Given this list of marker genes BCL2A1, TRABD, MSTO1, PRKN, THG1L, PID1, RCC1L, VAT1, YME1L1, ZDHHC6, NME3, BAX, MIGA2, MIEF2, AFG3L2, MFN2, TFRC, STOML2, BNIP3, MUL1 (mitochondrial E3 ubiquitin protein ligase 1), MTCH2, HUWE1, MIGA1, PARL, MIEF1, CHCHD3, MCL1, OPA1, FUNDC1, MFN1, PLD6, GDAP1, OMA1, BAK1, ADCK1, USP30, here is a description of the gene set: Human Gene Set: GOBP_MITOCHONDRIAL_FUSION species: Homo sapiens Merging of two or more mitochondria within a cell to form a single compartment.